The following is a description of a gene set: IL9 signaling studied in species Homo sapiens Human Gene Set: WP_IL9_SIGNALING, and this is the list of marker genes: IL9R, STAT1, IL9, IL2RG, JAK3, MAP2K2, STAT5A, STAT3, MAPK3, CDK9, STAT5B, JAK1, PIK3R1, MAPK1, PIK3R2, MAP2K1, GRB2